The following is a description of a gene set: species: Homo sapiens Human Gene Set: GOCC_AP_3_ADAPTOR_COMPLEX A heterotetrameric AP-type membrane coat adaptor complex that consists of beta3, delta, mu3 and sigma3 subunits and is found associated with endosomal membranes. AP-3 does not appear to associate with clathrin in all organisms. In at least humans, the AP-3 complex can be heterogeneric due to the existence of multiple subunit isoforms encoded by different genes (beta3A and beta3B, mu3A and mu3B, and sigma3A and sigma3B)., and this is the list of marker genes: AP3B1, VPS33A, AP3S2, VPS41, AP3D1, VPS39, AP3S1, AP3B2, AP3M1, VPS18, AP3M2